The following is a description of a gene set: A morphological abnormality of the vestibule, the central part of the osseous labyrinth that is situated medial to the tympanic cavity, behind the cochlea, and in front of the semicircular canals. Abnormal morphology of the vestibule of the inner ear studied in species Homo sapiens Human Gene Set: HP_ABNORMAL_MORPHOLOGY_OF_THE_VESTIBULE_OF_THE_INNER_EAR, and this is the list of marker genes: KCNJ10, LZTR1, KDM6A, NRAS, PTPN11, RRAS2, SPRED2, SLC26A4 (solute carrier family 26 member 4), SIX5, ESRP1, CBL, RRAS, RAF1, SOX10, KMT2D, SOS2, MAP3K7, EBF3, FOXI1, RASA2, FGFR2, FOXP2 (forkhead box P2), GREB1L (GREB1 like retinoic acid receptor coactivator), HRAS, SOS1, PI4KB, RIT1, MRAS, SIX1, SEMA3E, EYA1, KRAS, CHD7